The following is a description of a gene set: Heterozygous HNF1A mutations cause pancreatic-islet beta-cell dysfunction and monogenic diabetes (MODY3). Hnf1alpha is known to regulate numerous hepatic genes, yet knowledge of its function in pancreatic islets is more limited. We now show that Hnf1a deficiency in mice leads to highly tissue-specific changes in the expression of genes involved in key functions of both islets and liver. To gain insights into the mechanisms of tissue-specific Hnf1alpha regulation, we integrated expression studies of Hnf1a-deficient mice with identification of direct Hnf1alpha targets. We demonstrate that Hnf1alpha can bind in a tissue-selective manner to genes that are expressed only in liver or islets. We also show that Hnf1alpha is essential only for the transcription of a minor fraction of its direct-target genes. Even among genes that were expressed in both liver and islets, the subset of targets showing functional dependence on Hnf1alpha was highly tissue specific. This was partly explained by the compensatory occupancy by the paralog Hnf1beta at selected genes in Hnf1a-deficient liver. In keeping with these findings, the biological consequences of Hnf1a deficiency were markedly different in islets and liver. Notably, Hnf1a deficiency led to impaired large-T-antigen-induced growth and oncogenesis in beta cells yet enhanced proliferation in hepatocytes. Collectively, these findings show that Hnf1alpha governs broad, highly tissue-specific genetic programs in pancreatic islets and liver and reveal key consequences of Hnf1a deficiency relevant to the pathophysiology of monogenic diabetes. Human Gene Set: SERVITJA_ISLET_HNF1A_TARGETS_UP Genes up-regulated in pancreatic islets upon knockout of HNF1A. from publication Servitja JM, Pignatelli M, Maestro MA, Cardalda C, Boj SF, Lozano J, Blanco E, Lafuente A, McCarthy MI, Sumoy L, Guigó R, Ferrer J (PMID 19289501) studied in species Mus musculus, and this is the list of marker genes: SERPINA9, SERPINB1, CNN2, TGFB2, NR2F1, CXCL13 (C-X-C motif chemokine ligand 13), PHOX2B, KLK1, CACNG5 (NCBI Gene Id 27091), KCND2, HTRA1, PYGB, RAB6B, SEMA4F, FGF13, CTSC, PCOLCE, RBFOX1, PLXND1, SEPTIN4, STMN2, FST, GAB1, PLCB4, GALK1, VIM, HPS1, ITGB2, NOL3, NEFL, C1QB, RAB38, ITGA7, SLC15A3, FADS3, PROCR, EGR2, POSTN, CSF1, IFITM3, IFIT2, PTN, RBMS3, C1QC, PTPRO, SCARA3, NTM, NSG2, CPLX1, LGALS3, ABCC3 (NCBI Gene Id 8714), RHOC, ELAVL2, AKAP12, CAPG, MMP14, LYZ, OPLAH, DNM3, SPINK1, CACNA2D3, NRSN1, IFITM1, SDC1, PRKG2, CHL1, VIP, SLC16A1, NDRG2, ANXA2, PMP22, CIDEA, THBS2, LY6H, PLA2G4A, COL6A1 (NCBI Gene Id 1291), THY1, SLC6A15, VCAM1, CDH11, LAPTM5, DUSP26, ADCYAP1R1, SCARF2, CCN4, ATF3, SNAI2, DPT, CCL2, PNLIPRP2, SOX2, MSN, CEACAM4, GAP43, PCDH15, UCHL1, EGR3, FBN1, TGM2, EPHA5, EFEMP2, NEBL, CCL15, PARP3, HLA-DQA2, ADCYAP1 (NCBI Gene Id 116), SNCG, FGF14, C1S, HCN1, CAMK4, MEIS2, SYTL3, DKK3, ZNF521, MICAL1, TNFAIP2, CXCL12, SERPINH1, NOTCH2, AEBP1, DNM1, FABP7, MAF, BLVRB, SMAD3, ARHGDIB, ACOT7, EFEMP1, SNCA, COL5A2, AMY2B, IRGM, EPB41L2, SYCN, RNASE1, APOE, COL3A1, SERPINE2, ANXA1, ASS1, BGN, ADCY7, CYBA, TMEM47, TGFB3, MCAM (NCBI Gene Id 4162), SPARCL1, REST, SV2B, TSPOAP1, STK17B, STXBP5L, HLA-B, CNR1, KCNIP4, GUCY1A1, ID4, LGALS1, TIMP2, ZFHX4, GRM7, CYP1B1, COL18A1, MAP4, FSTL5, DCLK1